Given this list of marker genes PRDX2, EIF2D, CRABP2, CCNG1, CFH, ANXA8L1, here is a description of the gene set: Human Gene Set: CASTELLANO_HRAS_AND_NRAS_TARGETS_UP from publication Castellano E, De Las Rivas J, Guerrero C, Santos E (PMID 16909116) Genes up-regulated in MEF cells (embryonic fibroblasts) isolated from HRAS and NRAS double knockout mice. species: Mus musculus We characterized differential gene expression profiles of fibroblast cell lines harboring single or double-homozygous null mutations in H-ras and N-ras. Whereas the expression level of the individual H-, N- and K-ras genes appeared unaffected by the presence or absence of the other ras loci, significant differences were observed between the expression profiles of cells missing N-ras and/or H-ras. Absence of N-ras produced much stronger effects than absence of H-ras over the profile of the cellular transcriptome. N-ras(-/-) and H-ras(-/-) fibroblasts displayed rather antagonistic expression profiles and the transcriptome of H-ras(-/-) cells was significantly closer to that of wild-type fibroblasts than to that of N-ras(-/-) cells. Classifying all differentially expressed genes into functional categories suggested specific roles for H-Ras and N-Ras. It was particularly striking in N-ras(-/-) cells the upregulation of a remarkable number of immunity-related genes, as well as of several loci involved in apoptosis. Reverse-phase protein array assays demonstrated in the same N-ras(-/-) cells the overexpression and nuclear migration of tyrosine phosphorylated signal transducer and activator of transcription 1 (Stat1) which was concomitant with transcriptional activation mediated by interferon-stimulated response elements. Significantly enhanced numbers of apoptotic cells were also detected in cultures of N-ras(-/-) cells. Our data support the notion that different Ras isoforms play functionally distinct cellular roles and indicate that N-Ras is significantly involved in immune modulation/host defense and apoptotic responses.